Given this list of marker genes DEFB130B, DEFB133, DEFB4A, DEFB103B, DEFB1, DEFB114, DEFB109B, CCL20, DEFB130A, DEFB103A, DEFB110, here is a description of the gene set: Human Gene Set: GOMF_CCR6_CHEMOKINE_RECEPTOR_BINDING Binding to a CCR6 chemokine receptor. species: Homo sapiens